Given this list of marker genes P4hb, Bmp1, Col5a3, Loxl3, P3h2, Col19a1, Mmp7, Col11a2, Col13a1, Col18a1, Col12a1, Col7a1, Col20a1, Ppib, Col1a2, Pcolce (procollagen C-endopeptidase enhancer protein), Col4a6, Loxl4, Col24a1, Mmp3, Col17a1, Loxl2, Mmp13, Col6a5, Plod3, Col10a1, P3h3, Loxl1, Tll2, Col15a1, Col6a6, Col4a2, Pcolce2, Col8a2, Col2a1, Col6a1, Lox, Plod2, Col25a1, Col8a1, Ctss, Mmp20, Col9a1, Col4a5, here is a description of the gene set: Reactome Pathway: Collagen formation part of: Extracellular matrix organization electronically inferred by orthology from the curated human pathway This event has been computationally inferred from an event that has been demonstrated in another species.<p>The inference is based on the homology mapping from PANTHER. Briefly, reactions for which all involved PhysicalEntities (in input, output and catalyst) have a mapped orthologue/paralogue (for complexes at least 75% of components must have a mapping) are inferred to the other species. studied in species Mus musculus